The following is a description of a gene set: Muscarinic acetylcholine (mAChRs) receptors were so named because they are more sensitive to muscarine than to nicotine (Ishii M and Kurachi Y, 2006). Their counterparts are nicotinic acetylcholine receptors (nAChRs), ion channels receptors that are also important in the autonomic nervous system. Many drugs can manipulate these two distinct receptors by acting as selective agonists or antagonists. mAChRs bind to the bioamine acetylcholine, have a widespread tissue distribution and are involved in the control of numerous central and peripheral physiological responses, particularly voluntary muscle contraction. They are also major targets for drugs in human diseases such as Alzheimer's, Parkinson's and schizophrenia. This family of G-protein coupled receptors consists of five members designated M1-M5 and are sub-divided into two groups based on their primary coupling to G proteins. M2 and M4 receptors couple to Gi/o proteins and M1, M3 and M5 receptors couple to Gq/11 proteins (Caulfield MP and Birdsall NJ, 1998). Reactome Pathway: Muscarinic acetylcholine receptors part of: Amine ligand-binding receptors species: Homo sapiens, and this is the list of marker genes: CHRM3, CHRM4, CHRM2, CHRM1, CHRM5